Given this list of marker genes GBP4, OAS1 (2'-5'-oligoadenylate synthetase 1), MX2, OASL, GBP2, PSMB8, IFNGR1, IFI30 (NCBI Gene Id 126359), WARS1, IDO1, CXCL10, IFNGR2, IFIT2, IFITM1, OAS2, IFNAR2, GBP1, IFI44, CXCL9, IFIT1, GBP5, APOBEC3B, IFITM2, MX1, TRIM22, IFIT3, IFNAR1, SERPING1, SERPINA1, APOBEC3A, OAS3, IFI35, IFI27, here is a description of the gene set: from publication Sobolev O, Binda E, O'Farrell S, Lorenc A, Pradines J, Huang Y, Duffner J, Schulz R, Cason J, Zambon M, Malim MH, Peakman M, Cope A, Capila I, Kaundinya GV, Hayday AC (PMID 26726811) Genes down-regulated in peripheral blood mononuclear cell 7d vs 1d in adults (18-64) after exposure to Pandemrix, time point 7D Adjuvanted vaccines afford invaluable protection against disease, and the molecular and cellular changes they induce offer direct insight into human immunobiology. Here we show that within 24 h of receiving adjuvanted swine flu vaccine, healthy individuals made expansive, complex molecular and cellular responses that included overt lymphoid as well as myeloid contributions. Unexpectedly, this early response was subtly but significantly different in people older than ~35 years. Wide-ranging adverse clinical events can seriously confound vaccine adoption, but whether there are immunological correlates of these is unknown. Here we identify a molecular signature of adverse events that was commonly associated with an existing B cell phenotype. Thus immunophenotypic variation among healthy humans may be manifest in complex pathophysiological responses. studied in species Homo sapiens Human Gene Set: SOBOLEV_PBMC_PANDEMRIX_AGE_18_64YO_7DY_DN